Given this list of marker genes RPS4X, RPL11, RPL37, RPS3, RPS14, RPL19, EIF2AK4, RPLP0, RPS21, RPL26L1, FAU, RPS27L, RPL22, RPS20, RPL34, RPS10, RPL13, 5S rRNA, RPL30, RPL23, RPS5, RPLP1, RPL26, RPS29, RPL38, RPL41, RPS13, RPS19, RPS23 (NCBI Gene Id 6228), RPL7A, ASNS, RPS2, RPS3A (NCBI Gene Id 6189), RPL10L, RPL9, RPS15, TRIB3, UBA52, RPS27, IMPACT (NCBI Gene Id 55364), RPL35, EIF2S2 (NCBI Gene Id 9359), RPL27, RPL18, RPL5 (NCBI Gene Id 90045), RPL31, ATF4, RPS15A, ATF2, RPL27A, EIF2S3, RPL35A, RPL37A, RPL7, RPL39L, DDIT3, RPS4Y1, RPL36AL, RPS12, RPSA, RPS28, RPL3L, RPL10, RPLP2, RPL12, RPL28, RPL8, GCN1, 28S rRNA, RPS9, RPS4Y2, CEBPG, RPL10A, RPL3, RPL24, RPS27A, RPL13A, RPS17, RPS16, 18S rRNA, RPL17, RPL36, RPL23A, RPL39, RPL15, RPS8, RPL4, CEBPB, ATF3, RPS25, RPS7, RPL36A, RPS11, RPL29, RPL21, RPS26, RPL22L1, RPL32, RPL14, RPS18, RPS6, RPL18A, EIF2S1, 5.8S rRNA, RPS24, RPL6, here is a description of the gene set: part of: Cellular response to starvation species: Homo sapiens Reactome Pathway: Response of EIF2AK4 (GCN2) to amino acid deficiency EIF2AK4 (GCN2) senses amino acid deficiency by binding uncharged tRNAs near the ribosome and responds by phosphorylating EIF2S1, the alpha subunit of the translation initiation factor EIF2 (inferred from yeast homologs and mouse homologs, reviewed in Chaveroux et al. 2010, Castilho et al. 2014, Gallinetti et al. 2013, Bröer and Bröer 2017, Wek 2018). Phosphorylated EIF2S1 reduces translation of most mRNAs but increases translation of downstream ORFs in mRNAs such as ATF4 that contain upstream ORFs (inferred from mouse homologs in Vattem and Wek 2004, reviewed in Hinnebusch et al. 2016, Sonenberg and Hinnebusch 2009). ATF4, in turn, activates expression of genes involved in responding to amino acid deficiency such as DDIT3 (CHOP), ASNS (asparagine synthetase), CEBPB, and ATF3. In mice, EIF2AK4 in the brain may responsible for avoidance of diets lacking essential amino acids.<br>EIF2AK4 is bound to both the ribosome and GCN1, which is required for activation of EIF2AK4 and may act by shuttling uncharged tRNAs from the A site of the ribosome to EIF2AK4. Upon binding tRNA, EIF2AK4 trans-autophosphorylates. Phosphorylated EIF2AK4 then phosphorylates EIF2S1 on serine-52, the same serine residue phosphorylated by other kinases of the integrated stress response: EIF2AK1 (HRI, activated by heme deficiency and other stresses), EIF2AK2 (PKR, activated by double-stranded RNA), and EIF2AK3 (PERK, activated by unfolded proteins),